The following is a description of a gene set: studied in species Mus musculus Reactome Pathway: Inhibition of the proteolytic activity of APC/C required for the onset of anaphase by mitotic spindle checkpoint components This event has been computationally inferred from an event that has been demonstrated in another species.<p>The inference is based on the homology mapping from PANTHER. Briefly, reactions for which all involved PhysicalEntities (in input, output and catalyst) have a mapped orthologue/paralogue (for complexes at least 75% of components must have a mapping) are inferred to the other species. electronically inferred by orthology from the curated human pathway part of: Mitotic Spindle Checkpoint; Regulation of APC/C activators between G1/S and early anaphase, and this is the list of marker genes: Anapc2, Cdc26, Ube2e1 (ubiquitin-conjugating enzyme E2E 1), Anapc7, Ube2c, Cdc23, Mad2l1, Anapc10, Anapc15 (anaphase promoting complex C subunit 15), Ube2d1, Ube2s